Given this list of marker genes TSC22D2, PHLPP2, ATP1B1, WDFY3, KDM3A, CCNG2, DENND1B, NKAPD1, SHOX2, NKAIN2, RAD23B, LATS1, MKRN2, TCF7, HMGA2, SLAMF7, FAF2, RAD21, RP2, HNRNPDL, ZNF253 (NCBI Gene Id 56242), TMEM170A, AIDA, KHDRBS3, ZNF77, XBP1, NOVA1 (NOVA alternative splicing regulator 1), ZNF827, WASF1, ASPH, ESCO2, NOL4, TMEM245, PABIR3, GFOD1, MAPK6, SMAP1, RCOR3, MAX (NCBI Gene Id 4149), ELAVL1, FHIP2A, SUB1, ACSS3, NCAM1, STRN, PPFIA2, CCDC68, CAMK2D, MFHAS1, RBM15B, PLCXD3, VEZF1, PUM1, ZBTB20, SLC38A2, UBE2K, MIA3, BACH2, CA8, here is a description of the gene set: Genes predicted to be targets of miRBase v22 microRNA hsa-miR-4704-5p in miRDB v6.0 with MirTarget v4 prediction scores > 80 (high confidence targets). from publication Chen Y, Wang X (PMID 31504780) species: Homo sapiens Human Gene Set: MIR4704_5P